The following is a description of a gene set: studied in species Homo sapiens Binding to all-trans retinal, a compound that plays an important role in the visual process in most vertebrates. All-trans retinal (trans r., visual yellow) results from the bleaching of rhodopsin by light, in which the 11-cis form is converted to the all-trans form. Retinal is one of the forms of vitamin A. Human Gene Set: GOMF_ALL_TRANS_RETINAL_BINDING, and this is the list of marker genes: CYP2W1, ADH4, CYP27C1, ABCA4 (ATP binding cassette subfamily A member 4), OPN3 (NCBI Gene Id 23596)